Given this list of marker genes Sostdc1, Ddit3, Aida, Mapk8, Ctnnb1, Acvr1, here is a description of the gene set: species: Mus musculus Mouse Gene Set: GOBP_REGULATION_OF_DETERMINATION_OF_DORSAL_IDENTITY Any process that modulates the frequency, rate or extent of determination of dorsal identity.